Given this list of marker genes DECR2 (NCBI Gene Id 57382), ALDH1L2, PLA2G4A, PNLIPRP3, APOC2, ELOVL5, CYP7B1, SREBF1, ACACB, CEACAM1 (CEA cell adhesion molecule 1), AACS, NR1H2, PRKAA1, LDHD, SLC1A3, MGAT4A, HIF1A, ELOVL3, ACBD5, FABP5 (fatty acid binding protein 5), UCP3, UBR4, HAGH, HADH, IRS1, GSTM1, OLAH, PNLIPRP1, ACOX3, ELOVL7, GPX4, GBA2, FLCN, ENO4, GRHPR (glyoxylate and hydroxypyruvate reductase), CYP4Z1, AKT1, MIR204, ALOX12B, CES2, CRYL1, ACOT8, HACD3, HDAC4, CYP26A1, ELOVL2 (NCBI Gene Id 54898), CPT1B, TRIB3, IDH2, CYP1A1, PANK2, ADH6 (NCBI Gene Id 130), HACD2, PLA2G5, KIT, NDUFAB1 (NCBI Gene Id 4706), LPL, PPP2CA, P2RX7, GGT1, CYP4B1, APOC1, ME3, BCL2L13, MLXIPL, FAHD1, NUDT7, FADS1, SCP2, ERLIN1, EDN1 (NCBI Gene Id 1906), VDAC1 (voltage dependent anion channel 1), TBXAS1, LIPG, PPARA, ACOT2, PLA2G15, LDHA, PGAM4, ME2, STARD4, HACL1, ACOX2, OSBPL3, ALDH1A3, CYP1B1, HAO2, PFKFB3, FADS6, UGT1A8, NCOR1, ANGPTL3, PTGDS, C3, ME1, ACSM4, ACACA, PTGR1, PRKAA2, ARL2, ADH5, THEM4, ASAH1, MSMO1, PLA2G4C, AOAH, AWAT1, ENO2, SIRT6, PGK2, SGPL1, PNLIPRP2, HSD17B8, CPT1C, ABCB11, AKR1C3, PLA2G2F, FMO1, MGST3, BTD, ZBTB7A, GAPDHS, INSIG2, FAAH2, ACSBG1, CYP26C1, OSBPL6, SLC4A1, CTHRC1, FBP1, INSR, CYP4A11, ABCD4, FADS3, FKRP, OSBPL1A, PEX13 (peroxisomal biogenesis factor 13), HAAO, PLIN5, ACAA1, ACOT7, CRABP2, GPIHBP1, ACADSB, ALDH1A1, LPIN3, BDH2, ALDH3A2, PRKAB1, CYP3A4, IGF1, ACOT6, LPGAT1, UGT1A9, SLC27A1, ETFBKMT, ACOXL, CBR1, PLA2G4F, ECH1, CYP2S1, ABHD3, ACADM, CYP2C9, FA2H, DGAT2, CYP2A13, ADH7, SLC25A16, KLHL25, ALKBH7, DHTKD1, CYP2C8, ASPA, PLA2G4D, THEM5, HOGA1, SCPEP1, PRMT3, COL6A1, CYP2J2, UGT1A6, PLP1, UGT1A10, GSTP1, HAO1, OSBPL2, SIRT4, AUH, PLA2G10, AKR1B1, ACSM6, FADS2B (fatty acid desaturase 2B (pseudogene)), ECHS1, PNPLA3, CYP27A1, PCK1, HLCS, MID1IP1, MMUT, SLC6A8, PNKD, AASDHPPT, PEDS1, PTGS1, UCHL1, PHYH, CYP2A7, DAGLA, PCK2, ACSS2, HSD17B10, MIR182, ADIPOR2, MPC2, CBFA2T3, ABCD2, FABP2, LDHB, TWIST1, ALOX12, PRKAG2, CES1, ALDH1A2, MFSD2A, CYP4F2 (cytochrome P450 family 4 subfamily F member 2), ALDOA, ATP8B1, UCP2, APOA4, CYP2F1, SLC25A42, TMEM135, ACSL5, KYNU, XBP1, HSD17B12, CYP3A5, ADH1B, ACADVL, CYP7A1, ABCD1 (NCBI Gene Id 215), PPARD, THNSL2, ECI1, FAAH, ACSL6, MIR210, LDHC, TRIM63, CYP2A6, GAMT, CYP4F12, ALOXE3, DAGLB, ADIPOR1, ASAH2, GAD2, IER3, APOC3, NDUFS6, GAPDH, ECHDC2, ABHD1, PTGS2, LONP2, INS, ETFA, DEGS1, LDHAL6A, ACSM1, MIR766, AKR1A1, ADH1C, HK2, SLC27A3, NUDT19, PARK7, NFE2L1, MBLAC2, CYP4F11, GIP, HSD3B7, PDHA2, UGT2A1, SLC38A1, ADIPOQ, GSTA1 (NCBI Gene Id 2938), PGK1, PRKAB2, TYSND1, HKDC1, LYPLA1, TNXB, OSBPL7, IDO1, VNN2, ADH1A, SULT2A1, NPC1, NR1D1, FGF19, TECR, GLYAT, PGAM2, CYP39A1, AGXT2, GCK, GCDH, POR, BCO2, ALOX15B, NR1H3, ACOT4, ABHD5, CYP2D6, PRKAR2B (protein kinase cAMP-dependent type II regulatory subunit beta), TYRP1, HTD2, CYP4V2, PIBF1, KAT2B, CYP26B1, LTC4S (NCBI Gene Id 4056), MTHFD1L, HPGD, SLC16A3, SLC2A6, HSD17B4, GLYATL2, AKT2, TECRL, ACSM2A, OGDHL, ARNT, ACOX1, CYP2E1, ENO3, ACTN3, ZBTB20, ALOX15, FABP3, MTOR, HPGDS, EDN2, WDTC1, GPD1, MCEE, BAAT, ERFE, CBR4, AASDH, ABAT, MTLN, IVD, MIR185, MIR132, LDHAL6B, SNCA, ALDH5A1, MIR30C1, ACAD10, SLC27A2, CYP4F8, ACSL4, ACOT12, APOA5, BRCA1, EP300, SLC27A5, ACAT1, ACOT1, SORD, OSBPL9, CYP2C18, MIR342, OGT, UGT1A4, UROC1, ACBD4, CYP2U1, CYP2B6, HACD4, SDS, MIF (macrophage migration inhibitory factor), MAPK14, GHSR, GPAM, PHGDH, DBI, ETFDH, TPK1, FMO4, LIPC, ELOVL6, ACSM2B, PDHX, LPIN2, ACSBG2, CPT2, STAT3 (NCBI Gene Id 6774), RPTOR, ADPGK, PFKFB1, ACSS1, INSIG1, SIRT2, CROT, PPARGC1A, UGT1A1, PEX7, GATD1, OXSM, DDIT4, UGT1A3, MORC2, ACAD11, PCCB, PDHA1, CAV1, ABHD6, LPIN1, SIRT1, PC, AGXT, PLA2G3, ERLIN2, ADH4, FTCD, MTHFS, PM20D1, PNPLA8, FOXK1, D2HGDH, ECI2, ABCC9, SOX9, CYP1A2, PTGES2, PRKAG3, AMACR (NCBI Gene Id 23600), ILVBL, XYLB, PER2, AKR1C4, MCAT, ACSL1, PFKP, ACSM5, PRKAG1, LIAS, ALDOB, COMT, SRR, FGFR4, MFSD8, CD36, AMDHD1, ACSL3, PDK3, HK3, ELOVL4 (NCBI Gene Id 94678), MIR96, PANK4, SLC4A4, GPX1, EPHX1, PRXL2C (NCBI Gene Id 203335), ACBD7, UGT2A2, PDK1, GGT5, PGM1, GPI, PSEN1, PROX1, FMO2, MIR33A, ECHDC1, ACAT2, ALOX5, GIT1, MIR548P, SCD, NUPR1, AVPR1A, ACOT11, VNN1, ATP6V1B1, ARV1, AKR1C2, PGD, SHMT2, PCCA, CPT1A, PECR, IFNG, PFKM (NCBI Gene Id 5215), LEP, UGT1A7, SLC22A13, MTHFD2 (methylenetetrahydrofolate dehydrogenase (NADP+ dependent) 2, methenyltetrahydrofolate cyclohydrolase), TREX1, ACSF3, GALK1, AVP, ANGPTL4, GAD1, DECR1, PDHB, TIGAR, PNLIP, PDK2, MECR, STAR, FAH, KMO, HK1 (hexokinase 1), CYP3A7, GDF15 (growth differentiation factor 15), GATM, ACSF2, PRXL2B, ERRFI1, PLA2G4B, MGLL, BPGM, MLST8, PTGES3, PEX2, OSBP, EHHADH, HADHA, PRKACA, OGDH, ALDH8A1, PKM, HYI, ENSG00000293349, ENO1, NR1H4, LYPLA2, SLC27A4, ACAD9, CRAT, PTGR2 (prostaglandin reductase 2), IRS2, PPARG, PFKL, ACOT9, CYP46A1, ADTRP, ECHDC3, ACMSD, SLC45A3, MCCC1, TNFRSF1A, QKI, PKLR, EIF6, RBP1, CYP2W1, DCAF5, ACADS, CD74, HAL, PLAA, ACAA2, SLC16A1, GPAT4, IL1B, ABCD3, HADHB, LIPA, ELOVL1, ABHD12 (NCBI Gene Id 26090), DCXR, ABHD2, APPL2, IL4I1, NUDT8, DLAT, PLA2G1B, HACD1, ALDOC, SRC, MRS2, TPI1, SCAP, PDK4, FASN, SCD5 (stearoyl-CoA desaturase 5), CYP4A22, SLC5A6, FOXK2, MALRD1, SESN2, PFKFB2, APP (NCBI Gene Id 351), MTCH2, RDH10, FADS2, PTGIS, PEX5, ACSM3, DLD, PGAM1, PTGES, CYP8B1, SLC27A6, SLC25A17, ACLY, CYP4F3, NAAA, ANKRD23, CYP27C1, ACADL (NCBI Gene Id 33), CYP2C19, AKR1C1, TP53, GSTM4, AKR1D1, BCKDK, ETFB, AIG1, CYGB, GSTM2, NR5A2, JMJD8, HTR2A, MLYCD (NCBI Gene Id 23417), DHRS9, IDH1, here is a description of the gene set: species: Homo sapiens Human Gene Set: GOBP_MONOCARBOXYLIC_ACID_METABOLIC_PROCESS The chemical reactions and pathways involving monocarboxylic acids, any organic acid containing one carboxyl (COOH) group or anion (COO-).